The following is a description of a gene set: from publication Kaji T, Ishige A, Hikida M, Taka J, Hijikata A, Kubo M, Nagashima T, Takahashi Y, Kurosaki T, Okada M, Ohara O, Rajewsky K, Takemori T (PMID 23027924) To obtain insight into the genetic basis of the increase of functional activity of memory B cells over time, we compared the gene expression profiles of day 7 and day 40 NP-specific/IgG1 memory B cells, GC B cells and plasma cells in immunized WT mice and naïve B cells, before and after activation in vitro. Genes down-regulated in day 7 memory B cells versus day 7 plasma cells. species: Homo sapiens Human Gene Set: GSE11961_MEMORY_BCELL_DAY7_VS_PLASMA_CELL_DAY7_DN, and this is the list of marker genes: MBOAT1, CISH, ADGRG3, ZCCHC12, ZFHX3, SH3GLB2, RPAIN, AAK1, TGFB1I1, ARHGAP9, FBXO44, NEFH (neurofilament heavy chain), SNTB2, ID2, ACACB, IFNGR1, RRAGD, CSF2, PLEC, SMC5, GPRIN1, TNFRSF1A, OLIG3, PLCXD2, YWHAZ, SSBP2, DAP, ANXA2, NUP50, LHX2, MRPS6, ZNF804A, FXYD5, PRKAR2A, RNF19A, SPN, ATP10A, WBP4, DHRS7, SPATA13, MEX3B, OSM, MARVELD1, CTLA4, VWA3A, GABARAPL1, LGALS1, OSTM1, MBP, GREM1, NUDT16L1, NMRK1, TNFSF14, LPIN1, ATP5MK, SYDE1, POP7, TNIK, RGMB, NINJ2, DENND2C, ITGA6, AHI1, TAPT1, KLHDC3, TM9SF2, EGFL8, MAGEB5, KIN, HIGD2A, DUSP5, TTLL12, FGF13, KLHL9, RAP1B, SCARB1, SUOX, SLC35G1, ADCY6, NME7, CCDC88B, CABLES1, ARL4A, KRT26, MNS1, BMPR2, TAF1B, MRS2, PREB (prolactin regulatory element binding), FBXO17, C21orf58 (NCBI Gene Id 54058), HS2ST1, PDLIM1, FDX1, CNGA1, P3H4 (prolyl 3-hydroxylase family member 4 (inactive)), CMSS1, ITGAL (integrin subunit alpha L), ACOXL, C3orf38, IFNG, LDLRAP1, FAM72A, STK38, SLC26A2, CA12, AADAC, CDK6, PANX1, PKHD1L1, PARS2, DDX60 (DExD/H-box helicase 60), NFE2L2, CA5B, IGFLR1, ARID5A, SORT1, DNAJB6, TRPM1, GPRIN3, SH2D2A, IFIT1 (NCBI Gene Id 8374), PATJ, TFDP1, STARD4, RPS6KL1, ABHD8, B3GALT6, TNFSF10, CEP19, SHISA2, MYB, SATB1, NHERF1, ARRDC4, DDHD2, RSPH6A, ADAMTS10, IFT57, IL31, PLEKHG6, MEMO1, ICAM5, TNFRSF14, SAMD1, FHL2, CRY1, SMAD4, KLF3, NKX3-2, ACCS, DPP4, CAMK2G, DNAJA4 (DnaJ heat shock protein family (Hsp40) member A4), LYVE1 (lymphatic vessel endothelial hyaluronan receptor 1), SLC39A1, GPR146, STX1A, TNS1, RAB3IP, SYTL1, STK39, FLOT1, ADAD1, ARHGAP31, EID3, PTGER3, MXD1, CBR1, BICDL1, ENTREP3, WWTR1, AP1AR, HSF5, DNAI4, UNC5CL, FRRS1, APLP1, TERF2IP, SLC25A24, UTRN, DNER (NCBI Gene Id 92737), INSL6, PTPN12, RAD18, NTPCR, ARHGAP5, SLC17A6, DSE (NCBI Gene Id 29940), WFIKKN2 (NCBI Gene Id 124857), IZUMO4, DOCK5, TIMELESS, CDON, IL2RA, PSMA2, ACOD1 (NCBI Gene Id 730803), P4HTM, ALKBH4, DUSP10